The following is a description of a gene set: Binding to an amino acid, organic acids containing one or more amino substituents. studied in species Mus musculus Mouse Gene Set: GOMF_AMINO_ACID_BINDING, and this is the list of marker genes: Gad1 (NCBI Gene Id 228010), Ido1, Srr, Gad2, Cep104, Fmo3, Gchfr, Shmt1, Tat, Ubr2, Glud1, Gldc, Slc1a3, Glra1, Slc7a6, Gclc, Glrb, Gpr143, Ddc, Glra4, Mat1a, Grik1, Ass1, Grin3a, Prodh, Slc1a1, Grin2b, Kars1, Grin1, Cad, Got2, Sesn2, Hdc, Nos3, Shmt2, Rars1, Scly, Glra3, Ubr1, Grm7 (NCBI Gene Id 232326), Grin2a, Dpys, Sesn3, Mat2a, Slc6a13, Tdo2, Thnsl2, Nos2, Otc, Aars1, Gnmt, Mtr, Pah, Glra2, Glul, Tm4sf5, Grin2d, Ddah1, Cps1, Th, Casr, Agxt, Yars2, Slc6a11, Castor1, Gss, Slc38a9, Gfpt1, Grin3b, Sesn1